The following is a description of a gene set: studied in species Homo sapiens Human Gene Set: GOBP_REGULATION_OF_SOMATIC_STEM_CELL_POPULATION_MAINTENANCE Any process that modulates the frequency, rate or extent of somatic stem cell population maintenance., and this is the list of marker genes: HNF1B, MIR145, TAF5L, PAX8, PAX2, LBH, BMP7, SMO, TAL1, TAF6L, TP63, MYC